The following is a description of a gene set: Mouse Gene Set: GOBP_POSITIVE_REGULATION_OF_CATALYTIC_ACTIVITY Any process that activates or increases the activity of an enzyme. studied in species Mus musculus, and this is the list of marker genes: Tsacc, Ddr2, Zfp91, Mbp, Sipa1l1, Vangl2, Bcr, Notch2, Pxn, Csf1, Stk11, Fgd2, Spatc1l, Adra2c, Epm2aip1, Sirt3, Pdgfa, Sdhaf4, Rsu1, Ccdc125, Rab11fip2, Phactr4, Pnlip, Polg2, Ctsh, Fzd8, Ncstn, Fzr1, Cacul1, Map3k12, Map2k6, Slc27a4, Ccl19, Mtor, Erbb2, Ndel1, Cacna1d, Cldn3, Msh6, Chaer1, Map2k4, Stub1, Wnt3a (wingless-type MMTV integration site family, member 3A), Rfc4, Adcyap1, Fermt2, Rps3, Ccdc88a, Abl2 (NCBI Gene Id 98214), Pim1 (NCBI Gene Id 18712), Dlg1, Fgd4, Agtr1b, Mmd2, Abi2, Map3k4 (mitogen-activated protein kinase kinase kinase 4), Daxx, Fgf18, Cox17, Fcer2a, Bcl2, Prex1, Npnt, Gnb5, Lhcgr, Wnk4, Tank, Skp1, Bmp2, Apoe, Cldn13, Stim1, Tpx2, Ntrk3, Asap3, Topors, Net1, Fgfr2, Ralgapa1, Psrc1, Setmar, Sgsm2, Xrcc4, Map4k2, Grn (granulin), Prtn3, Chi3l1, Ndufa4, Psmd10, Pip5k1a, Gpihbp1, Cdh3, Vegfc, Spdye4a, Mid1ip1, Erp29, Cav2, Clspn, Btg1, Msh2, Antxr1, Egf, Scarb1, Akt2, Rfc3, Fzd5, Pik3cg, Cd40, Ccn1, Traf4, Cd4, Thbs1, Adcy1, Tgfb2, Ern1 (NCBI Gene Id 97745), Sez6l, Usp17le, Dab1, Tirap, Stil, Coro1c, Vldlr, Cdk5, Chp2, Apoa1, Npm1, D1Pas1, Tlr1, Fbxw7, Tbc1d20, Iqgap1 (NCBI Gene Id 52178), Calm3, Chtf8, Rapgef1, Plek, Mapre2, Slc37a4, Nek10, Prkag2, Orai1, Apoa2, Stradb, Ralb, Plaa, Asxl2, Por, Ddrgk1, Pdgfc, Ric1, Gas6, Pdgfrb (NCBI Gene Id 18596), Fxn, Cldn4, Pik3r6 (NCBI Gene Id 432574), Rtn4r, Epha2, Pcna, Rcn3, Rgma, Dab2ip, Plk1, Pdgfb (platelet derived growth factor, B polypeptide), Edn2 (NCBI Gene Id 13615), Calca, Pot1a, Dennd1a, Ager (advanced glycosylation end product-specific receptor), Neurl1a, Syap1, Grhl3, Taok3, Ang4, Ccl19-ps3, C1qtnf9, Rasgrp1, Etaa1 (Ewing tumor-associated antigen 1), Gpr65, Ccs, S100a10, Tnfrsf11a, Edn3, Gsk3a, Snx13, Adcy8, Dstyk, Sez6l2, Arhgef7, Efna1, Wdr41, Psen1, Lep, Adra2a, Psap, Ccr7, Sfrp2, Ccl24, Lyn, Mtmr9, Coa8, Higd1a, Zfp622, Nedd9, Traf2, Ern2, Adcy4, Mrnip, Wrn, Tbc1d2, Ccl5, Trem2, Nos3 (NCBI Gene Id 71933), Pik3r5, Trib3, Rgp1 (NCBI Gene Id 68706), Rgs7, Plin5, Mastl, Thy1, Bcl10, Mre11a, Ang (NCBI Gene Id 11727), Fzd4, Lrp8, Apc2, Ptpn1, Prlr, Gch1, Adcy7, Fgf1, Map3k7 (NCBI Gene Id 93774), Ajuba, Park7, Itgb3, Arhgap6, Mef2c, Mst1r, Pih1d1, Fnta, Prkcd, Syk, Ripk3, Ube2l3, Xrcc6, Ppp1r3g, Ip6k2, Cemip, Gnal, Aph1b, Atp7a, Ppp2ca, Map2k2, Wdr59, Sgsm3, Crk, Gab1 (NCBI Gene Id 14388), Hmga2, Drd1, Psenen, Rangap1, Ccl26, Map3k13, Vsir, Adcy2, Fgfr4 (fibroblast growth factor receptor 4), Dbi, Pin1rt1, Rasgrp2, Agrn, Mapre3, Rgs1, Apoc2l, Ralgapb, Tgm2, Rapgef6, Ltf, Cd24a (NCBI Gene Id 12484), Plscr1, Rgs8, Rfc5, Rhoa, Iscu, Stox1, Abi3, Aph1a, Itga6, Zeb2, F2, Tlr6, Il34, Apoc2, Egfr, Src, Nr1h3, Map4k4, Strada, C9orf72, Gclm, Chrna7, Tsc1, Epha1, Pla2g5, Ceacam1, Rgs6, Gprc5b, Ins2, Ralgapa2, Abl1, Csf1r (colony stimulating factor 1 receptor), Emp2, Igf1, Ube2srt, Azin2, Nbn, Myc, Pten, Lars1, Lmo4, Traf6, Pik3ca, Ccnd2, Nrxn1, Prss22, Ptk2, Mt3, Tax1bp3, Pkp4, Jak2, Htr2b, S100a1, Pin1, Ang6, Mmd, Wnt5a, Nr1h2, Atpsckmt, Ube2s, P2rx7, Fcer1a, Arhgap24, Wdr24, Stx4a, Ang2, Kif14, Abr, Dock9, Dock11, Jtb, Grem1, Cacna1c (calcium channel, voltage-dependent, L type, alpha 1C subunit), Unc119, Dennd1b, Gpr39, Reln, Arhgap42, Tnf, Myo9b, Trib2, Fgf23, Il4, Ezh2, Cd74, Magi3 (NCBI Gene Id 99548), Kitl, Arrdc4, Mapk8, Rassf2, Ccnd3, Arhgap35, Adra2b, Als2, Fbn1, Nox4, Map3k11, Tom1l1, Bcar3, Epha4, Gsk3b, Rps2, Camk1, Rgs14, Rcc2, Tcim, Wnt11, Cartpt, Apoa5, Hnrnpu, Crkl, Rap1gap, Tiam1, Mmut, Bmi1, Tead1, Map2k7, Kit, Tpd52l1, Tm9sf5, Irak1, Tert, Agtr1a, Xrcc5, Edn1, Lilra5, Smcr8, C1galt1c1, Adora2b, Pdcd10, Ralbp1, Ssbp1, Arhgef16, Hmgn1, Ube2i, Cdc20, Arhgap11a, Cass4, Drd4, Nf1, Lmf1 (lipase maturation factor 1), Cenpe, Mex3b, Rhog, Adam9, Rapgef2, Cav1, Ccl19-ps1, Dhfr, Slc1a1, Foxj1, Bcas3, Tnfsf11, B3gat3, Scrib, Ccny, Chtop, Lgals9, Msh3, Nus1, Ifng, Fgfr3 (NCBI Gene Id 14184), Mapk8ip3, Rap1a, Ccl19-ps5, Dscc1, Tbc1d30, Cib1, Cripto, Pot1b, Rock1, Rasgrf1, Ttbk1, Rhoc, Cimap3, Prelid1, Map3k1, Srcin1, Tmem106b, Cdkn1a, Dock10, Prox1, Stat3, Trib1, Rfk, Wnt4, Kalrn, Zc3h15, Nr4a2, Apoh, Arhgef10, Apoa4, Spdya, Tenm1, Odam, Snx9, Calm2, Map2k1, Arap1, Il3, Ccl11, Lims1, Vcp, Cyp27b1, Btrc, Gdnf, Snca, Ptprc, Dvl3, Rgs10, Fgfr1, Pibf1, Tigar, Mapk14, Ppargc1b, Dynap, Vdr, Ftmt, Ptk2b, Cdk5r2, Rgcc (regulator of cell cycle), Chtf18, Sema4d, Map3k10, Agap2, Adrb2, Rad50, Card10, Tcl1, Itgb1, Dvl2, Irgm1, Sirt1 (sirtuin 1), Map3k5, Srgap2, Rgs16, Adipoq, Cdc25b, Slc8a2 (NCBI Gene Id 20542), Ccl19-ps4 (NCBI Gene Id 100040035), Dock8, Arhgef19, Dock7 (NCBI Gene Id 67299), Ntf3, Ins1, Tab1, Terf2, Dhx9 (DExH-box helicase 9), Arhgef5, Mapk3, Ccl19-ps6, Slc5a3, Syde1, Epo, Avpr1b, Cxcl13, Ppp2r3c, Ang5, Arrdc3, Sesn2 (sestrin 2), Nrg1, Tlr4, Lrrk2, Cab39, Cdc14b, Ddx3x, Rapgef3, Evi5l, Ywhab, Sh3bp1, Plxnb1, Insr, Mtss2, Agt, Slc11a1, Irgm2, Wnt9b, Acr, Hras, Calm1, Abi1 (NCBI Gene Id 214715), Raf1, Snx18, Adam17, Pak1, Adcy3, F2r, Rab3gap1, Calcr, Usp6nl, Axin1, Ppia, Vav1, Pabpn1, Dok7, F2rl1, Tab2, Ereg, Cops8, Igtp, Ccnd1, Evi5, Efna3, Aph1c, Rfc2 (NCBI Gene Id 80420), Dusp19, Map2k3, Ect2, Ripk1, Rack1, Ntrk1, Angpt1, Sod1, Flt1, Pde5a, Dynapl1, Chrna3, Eef1a2, Cd200, Itgb1bp1, Sash1, Cdk5r1, Il1b, Robo1, Tbc1d7, Creb3, Fgf2, Esr1, Gpld1, Akt1, Sez6, Maged1